Given this list of marker genes KLF1, CFH, CFHR3, C1GALT1C1, CAD, SLC4A1, KCNN4, SLC19A1, CFHR1, ADAMTS13, TRNT1, PIEZO1, CDAN1, here is a description of the gene set: Schistocytosis species: Homo sapiens The presence of an abnormal number of fragmented red blood cells (schistocytes) in the blood. Human Gene Set: HP_SCHISTOCYTOSIS